Given this list of marker genes H2-Q2, H2-M1, H2-M11, H2-T3, H2-Q4, H2-T22, H2-DMb2, H2-M10.6, H2-Ab1, H2-M10.3, H2-Q10, Cd74, H2-K1, H2-M9, H2-D1, H2-Ea, H2-M2, H2-T23, H2-Eb2, H2-Q1, H2-T10, H2-Aa, H2-Oa, H2-Q7, H2-M3, H2-DMb1, B2m, H2-M10.1 (histocompatibility 2, M region locus 10.1), Mr1, H2-Ob, H2-DMa, H2-Eb1, H2-M5, H2-M10.2, H2-Q6, H2-M10.5, H2-M10.4, here is a description of the gene set: species: Mus musculus A transmembrane protein complex composed of an MHC alpha chain and, in most cases, either an MHC class II beta chain or an invariant beta2-microglobin chain, and with or without a bound peptide, lipid, or polysaccharide antigen. Mouse Gene Set: GOCC_MHC_PROTEIN_COMPLEX